The following is a description of a gene set: Human Gene Set: MIR3620_5P from publication Chen Y, Wang X (PMID 31504780) Genes predicted to be targets of miRBase v22 microRNA hsa-miR-3620-5p in miRDB v6.0 with MirTarget v4 prediction scores > 80 (high confidence targets). studied in species Homo sapiens, and this is the list of marker genes: NAGA, PHF24, STK40, FBXL18, CRISPLD1, NCOR1, EIF5, TRAF3, TOX2, BEND6, UBAP2L, TMPRSS13, KLK13, NPY, TJAP1, WARS1, ADAT3, MDGA1, ZSWIM5, LAPTM5, ERI3, FBXO17, PLEKHA8, TMEM216, NCK1, MLLT6, GIPC3 (GIPC PDZ domain containing family member 3), MSANTD3 (Myb/SANT DNA binding domain containing 3), ADCY10, PLK2 (NCBI Gene Id 10769), CD1B, ITCH, CAMKK2, MBTD1, KCNH5, KIAA0930, SDC3, TAGLN, NIPSNAP1, CNKSR2, CHD5 (NCBI Gene Id 26139), GNAO1, MEF2A, FBXL16, STRIP1, TMBIM1 (transmembrane BAX inhibitor motif containing 1), TAB2, EAPP, ZIC4, CMKLR1, TRIM66, ZNF609